The following is a description of a gene set: Circulating chylomicrons acquire molecules of apolipoproteins C and E and through interaction with endothelial lipases lose a large fraction of their triacylglycerol. These changes convert them to chylomicron remnants which bind to LDL receptors, primarily on the surfaces of liver cells, clearing them from the circulation.<br>This binding and clearance process involves several steps and requires the presence of heparan sulfate proteoglycan (HSPG)-associated hepatic lipase (HL). The molecular details of LDLR binding, and of the following steps of remnant endocytosis, are inferred from those of the coorresponding step of LDLR-mediated low-density lipoprotein (LDL) endocytosis. Reactome Pathway: Chylomicron clearance part of: Plasma lipoprotein clearance studied in species Homo sapiens, and this is the list of marker genes: LDLR, LIPC, APOE, APOB, LDLRAP1